The following is a description of a gene set: The process of creating a trabecula in an organ. A trabecula is a small, often microscopic, tissue element in the form of a small beam, strut or rod, which generally has a mechanical function. Trabecula are usually but not necessarily, composed of dense collagenous tissue. species: Mus musculus Mouse Gene Set: GOBP_TRABECULA_FORMATION, and this is the list of marker genes: Adgrg6, Srf, Col1a1, Fbn2, Cav3, Egln1, Msx2, Ppargc1b, Thbs3, Ovol2, Cyp27b1, Slc40a1, Enpp1, Vdr, Fhl2, Fkbp1a, Vegfa, Grem1, Rbp4, Sfrp1, Tgfbr3, Mmp2, Hey2, Tek, Smarca4, Wnt10b, Adamts1, Bmp10, Nkx2-5, Chad